The following is a description of a gene set: from publication Schwartz JT, Bandyopadhyay S, Kobayashi SD, McCracken J, Whitney AR, Deleo FR, Allen LA (PMID 22986450) We demonstrated recently that both constitutive and FAS-triggered apoptosis of human neutrophils are profoundly impaired by Francisella tularensis, but how this is achieved is largely unknown. To test the hypothesis that changes in neutrophil gene expression contribute to this phenotype, we used human oligonucleotide microarrays to identify differentially regulated genes in cells infected with F. tularensis strain LVS compared with uninfected controls. In order to examine the effect of F. tularensis on the neutrophil transcriptome, we performed microarray expression analysis on human neutrophils treated with F. tularensis subsp. holarctica live vaccine strain (LVS). Human Gene Set: GSE37416_0H_VS_3H_F_TULARENSIS_LVS_NEUTROPHIL_UP species: Homo sapiens Genes up-regulated in comparison of control polymorphonuclear leukocytes (PMN) at 0 h versus PMN treated with F. tularensis vaccine at 3 h., and this is the list of marker genes: IFT25, ARGLU1, GPR155, GAB1, TMCC1, PYGL (NCBI Gene Id 5836), AMD1, MALSU1, PCNP, ING1 (inhibitor of growth family member 1), PGLYRP1, JAK2, CMTM7, RAMAC, NDC80, SLC25A44, GIMAP4, HTATIP2, COPS7A, TM2D1, TMEM250, LSM2, RAB18, LNPEP, MTM1, NDUFB1, RNF34, SNX2, VPS26B (VPS26 retromer complex component B), YPEL3, HDAC5, CTBP2, NUDT5 (NCBI Gene Id 11164), MPPE1 (metallophosphoesterase 1), MNDA, MPZL1, ATP13A1 (NCBI Gene Id 57130), ATF6B, STX10, RABGAP1L, SNAP23, SUPT16H, PNISR (NCBI Gene Id 84956), SMARCD2, CSNK2A1, NASP, TMX1, NMNAT1, PRP4K, INO80E, SHISA5, FRY, CD300LF, ABHD18, FAM219A, NRF1 (NCBI Gene Id 4899), APAF1, MINDY1, ASH2L, BAG4, CERS2, NFS1, NSFL1C, PTTG2, UPF2, PLGRKT, SUOX, TM7SF3, TST, DHRS9, ZNF324, HENMT1, RECQL, SNRNP70, HAUS3, HADHA, UBE3B, CCDC126, DEF8, TBC1D22A, NRDC, FES, OXR1, KCTD18, HACD4, CARD6, NBR2, SNORA28, ASF1B, MARK2, GRAMD1C, FAM200B, GIMAP2, MSRB2, CYBA, C21orf91, UBE2D1, EPB41, OSBPL8, CAPRIN2, TTC9C, CAMK2G, CYB5R4, CD33, TMEM69, FBXL4, FKBP9, CASP2, RNF123, AGGF1, STRADA, CCP110, TRAPPC2, MVP, SNX11, BRI3BP, ACAP1, TSHZ3, ZNF652, H2AC6, CEP85L, RPAP3, R3HDM4, RNASET2, UHMK1, MRPL44, ZNF468, CAPN1, CEP19, PSMF1, ADAR, GIGYF2, C2CD2L, SMAP2, WRAP73, PGLS, TSC1, LUC7L3, CYBC1, ABHD3, ATP5F1E, MED25, ZNF443, CCNJL, RAB7A, RNF6, CISH, FBXL20, RCBTB2, GEMIN7, TATDN3, ARHGEF3, CIAO2A, MIR21, NUDT16, NT5C3A, CSTA, FCGR3B, ARHGAP9, TIGD3, UBE2R2, SMARCC2, OTULINL, FYB1, CNOT3, HIPK2 (NCBI Gene Id 653052), RMI1 (RecQ mediated genome instability 1), SCAMP1, RBM6, ASB7, LIN37, SRSF4, HK3, R3HDM2, DUSP12, NPTN, JAML, MAU2, IPCEF1, FNTB, PDCD6IP, CXorf38, DPEP2, ACTN4, MBOAT1, ACTR2, MAP3K1, ADD1, TBC1D20, SLC35A1, FEZ2, GNAQ, DDX46, TRAPPC1, C2orf68, DSN1, LAMTOR1, XPO1